Given this list of marker genes NHLH2, NDNF, NRP1, PLXNA1, UBB, PLXNA3, NRP2, SEMA3E, here is a description of the gene set: The process in which a relatively unspecialized cell acquires specialized features of a neuron located in the hypothalamus. These neurons release gonadotrophin-releasing hormone as a neural transmitter. Human Gene Set: GOBP_HYPOTHALAMUS_GONADOTROPHIN_RELEASING_HORMONE_NEURON_DIFFERENTIATION species: Homo sapiens